Given this list of marker genes CRY2, CLOCK, PER3, PER2, PER1, BMAL1, RORA, KMT2A, NR1D1, CRY1, CREBBP, here is a description of the gene set: studied in species Homo sapiens Reactome Pathway: Phosphorylation of CLOCK, acetylation of BMAL1 (ARNTL) at target gene promoters part of: Circadian clock After phosphorylated BMAL1:CLOCK heterodimers bind E-box elements in the promoters of target genes, CLOCK acetylates BMAL1 (inferred from mouse homologs in Hirayama et al. 2007) and becomes hyperphosphorylated through an incompletely characterized mechanism (inferred from the mouse homolog in Yoshitane et al. 2009, Robles et al. 2017). The hyperphosphorylation appears to both increase transcriptional activation activity and increase proteolytic degradation of CLOCK.